The following is a description of a gene set: Genes positively differentially expressed in cell type: CD8+ T cell upon treatment with cytokine: IFN-α1 in mouse lymph nodes in vivo. Mouse Gene Set: CUI_T_CELL_CD8_IFNA1_RESPONSE_UP Cytokines mediate cell-cell communication in the immune system and represent important therapeutic targets. A myriad of studies have highlighted their central role in immune function, yet we lack a global view of the cellular responses of each immune cell type to each cytokine. To address this gap, the authors created the Immune Dictionary, a compendium of single-cell transcriptomic profiles of more than 17 immune cell types in response to each of 86 cytokines (>1,400 cytokine-cell type combinations) in mouse lymph nodes in vivo. A cytokine-centric view of the dictionary revealed that most cytokines induce highly cell-type-specific responses. For example, the inflammatory cytokine interleukin-1β induces distinct gene programmes in almost every cell type. A cell-type-centric view of the dictionary identified more than 66 cytokine-driven cellular polarization states across immune cell types, including previously uncharacterized states such as an interleukin-18-induced polyfunctional natural killer cell state. species: Mus musculus from publication Cui A, Huang T, Li S, Ma A, Pérez JL, Sander C, Keskin DB, Wu CJ, Fraenkel E, Hacohen N (PMID 38057668), and this is the list of marker genes: Ifi44, Nars1, Sp140, Ms4a6d, Zcchc2, Ptma, Tor3a, Morc3, Irgm1, Mthfd2, Mov10, Vps37b, Hsp90aa1 (heat shock protein 90, alpha (cytosolic), class A member 1), Gpr18, Treml2, Pgd, Trim25, Psme2b, Hspa8, Ghitm, Ifi47, Cd274, Zup1, Capza2, Ppa1, Tmbim6, Ms4a6b, Pstpip1, Iigp1, Sp110, Ifi209, Etv6, Plscr3, Isg15, Laptm4a, Ranbp1, Psma4, Cxcl10, Hk1, Rnf114, Trim34a, Tor1aip1, Gbp3, Evi2a, Gbp6, Desi2, H2-K1, Pdia3, Uba1, Tapbpl, Ifi214, Tap1, Phf11c, Arfgef1, Cmpk2, Tmem243, Keap1 (kelch-like ECH-associated protein 1), Ppp6r1, Nt5c3, Nampt, Chmp4b, Psma2 (proteasome subunit alpha 2), Nes, Hspd1, Myd88, Hspbp1, Ogfrl1, N4bp1, Ifi203, Dtx3l, Igfbp4, Dusp28, Pnpt1, Gmppb, Adar, Psma7, Zc3hav1, Smchd1, Gpr65, Prrc2c, Igtp, Ccrl2, Tbrg1 (NCBI Gene Id 21376), Csrp1, Apobec3, Ncl, Mitd1, Irf7, Dhx58, Trim56, Clec2d, Ifih1, Tnfsf8, Mrpl30, Daxx, BC051226, Lpp, Phgdh, Stoml1, Selenow, Tmem192, Rabepk, Cmc1, Trim30c, Ms4a4b (membrane-spanning 4-domains, subfamily A, member 4B), Gbp9, Phip, Eif4a1, Tgtp1, Ifit1bl1, Cnp, Itpr1, Gtpbp2, Hspa9, Snrpd1, Irf9, Oas3, Cars1, Fnbp4, Lgals3bp, Psmb8, Ttc39b, Samhd1, Rigi, Ly6c2, Oasl1, Ifit3b, Irf8, Slfn5, Cpne3 (copine III), Psmb10, Psma3, Svbp, Trim30d, Ly6a, Ubc, Nmi, Gbp4, Wars1, Dbnl, Trafd1, Hspa5, Cacybp, Oas2, Naa20, Asb13, Phf11a, Atp8b4, Srsf7, Wdr43, Dkc1, Sh3glb1, Pim1, Phc2, Ubb, Parp12, Mndal, Ascc3, Gbp2 (guanylate binding protein 2), B2m, Tor1aip2, Psme1, Psmb9, Ddx39b, Gbp8, Cd47, Ms4a4c, Ccnd2, Phf11b, Vps54, Eif2s2, Psma5, Slc25a22, Shisa5, Ifit2, Ifi27l2a, Ilrun, Ly6e, Herc3, Cct3, Atm, Pdlim2, Tap2, Isg20, Ogfr, Stat1, Ifi213, Slco3a1, Max, Art2b, Casp8, Plaat3, H2-Q4, Fam111a, Oas1a, Clic4, Trim21, Gadd45g, Setdb2, Srsf3, Nop56, Hsh2d, Rmi2, Notch1, Tcof1, Cd86, Gzmb, Ddx60, Etnk1, Herc6, Actr2, Calhm6, Tnfsf10, Idnk, Eomes, Gbp5 (NCBI Gene Id 229898), Rbck1, Epsti1, Msn, Akr1b1, Cd164, C1qbp, Plac8, Pml, Ubald2, Lsm6, Irf1, Usp25, Cycs, Taldo1, Lgals9, Slamf7, Vars1, Arf4, Erap1, Ifi206, Stat2, Vcpip1 (valosin containing protein (p97)/p47 complex interacting protein 1), Fam241a, Irgm2, Cd53, Inpp1, Cd2, Ywhaz, Parp11, Stat3, Tut4, Socs1, Helz2, Cntrl, Mycbp2, Nsd3, Ifi208, Gbp7, Ssrp1, 9930111J21Rik2, Bst2, Lsm4, Pcgf5, Il2rg (NCBI Gene Id 16186), Emb, Cd69, Trim12c, Tmem184b, Rnf213, Usp18, Tapbp, Ifitm3, Ddx24, Shmt2, Pmepa1, Rsad2, H2-M3, Ifit3, Dpp4, Gng2, Gzma, Tuba1b, Xaf1, Dnaja1, Tcp1, Marchf5, Srm, Mvb12a, H2-T23, B4galt5, Tcstv4, Nlrc5, Tspo, Sdc3, Snx2, Xcl1, Zbp1 (NCBI Gene Id 80562), Map2k1, Ube2l6, Med28, Rfc3, Cnot6l, Parp14, Mgat1, Icam1, Hectd1, Eif5a, Uba7, Rtp4, Parp9, Ctss, Tgtp2, Tlr7, Trim26, Samd9l, Oasl2, Tasor2, Itm2b, Psme2, Parp10, Sell, Aida, Sp100, Rab5c, Luzp1, Rbl1, Atp8a2, Slfn1, Ifi204, Slfn8, Larp1, St6galnac4, Mif, Fchsd2, Tbc1d1, Mx1, Aldoa, Sh3gl1, Slfn2 (schlafen 2), Stip1, Ube2l3, Lgals8, Znfx1, Bbx, H2-D1, Ncoa7 (nuclear receptor coactivator 7), Dnajc7, Socs3, Jaml, Eif2s1, Ezr, Txn1, Cd2ap, Ifi35, Grina, Ifit1, Ran, Nup210, Sub1, Trim30a, H2-T22, Trim12a, Eif2ak2, H2-Q7, Snu13